Given this list of marker genes Cacng3 (calcium channel, voltage-dependent, gamma subunit 3), Lgi4, Lgi2, Adam11, Dlg4, Stx1a, Lgi3 (NCBI Gene Id 213469), Cacng4, Lgi1, here is a description of the gene set: species: Mus musculus part of: Developmental Biology electronically inferred by orthology from the curated human pathway This event has been computationally inferred from an event that has been demonstrated in another species.<p>The inference is based on the homology mapping from PANTHER. Briefly, reactions for which all involved PhysicalEntities (in input, output and catalyst) have a mapped orthologue/paralogue (for complexes at least 75% of components must have a mapping) are inferred to the other species. Reactome Pathway: LGI-ADAM interactions